Given this list of marker genes ATP5F1A, LPO, ATF7IP2, RNF166, FES, SQOR, MYO1G, LIPF, PRKAR1A, AP3D1, IFT22, TMEM163, CCL4, RHOQ, TNFSF9, ADRB2, CTPS1 (NCBI Gene Id 1503), PTP4A3 (protein tyrosine phosphatase 4A3), OPA3, LPIN1, HIF1A, MTCH1, RRAGA, CENPN, EEPD1, METRNL, IRF6, PURB, RBM14, AKNA (AT-hook transcription factor), MAP4K1, HSP90AB1, IL1RL1, FASLG, DNPH1, RTP3, GSK3B, ITGAX, GMIP, PPP3CB, KIF4A, CRLF1 (cytokine receptor like factor 1), CDC42SE1 (CDC42 small effector 1), LIPC, HGSNAT, SLC29A1, ADAM19, GLRB, ZRSR2, BMX, NCALD (neurocalcin delta), PA2G4, RAB3A, SLC2A1, GABARAPL1, MNT, SFRP2, NFIC (nuclear factor I C), CNPPD1 (cyclin Pas1/PHO80 domain containing 1), PRDM1, ETHE1, FCGRT, CEMIP2, ERRFI1, DCXR, PGLS, DSCAML1, DIAPH1, GADD45G, TAX1BP3, CCR5, EHBP1L1, PGK1, PDIA4, DDC, SLC20A1, SLC2A3, TNFAIP1, NRM, CD37, TIAM1 (TIAM Rac1 associated GEF 1), SLAMF7, GNA11, UNC119B, FAM107B, PGP, TTN, CTLA4, WNK4, ARL4C, ATP1B1, LFNG, ORAI1, OTULIN, CTSA, VIM, EIF3F, CALU, LAGE3, CCNI, SMARCD2, CHST12, KIAA0319L, THBS4, IFNG, XCL1, GRIN2D, PTPRCAP, PPP1R21, CDKN2D, DDIT4, PELO, TLN1, REEP5, PPM1G, TNNI2, FEM1A, COMMD4, RBPJL, IL21R, NAGK, ADIPOR1, ADAMTSL5, FLVCR1, SSPN, RHOH (NCBI Gene Id 399), HEPACAM2, RER1, LCN2, DENND1B, SEMA4B (semaphorin 4B), PCBP2, GLRA4, SOCS3, SNTB2, PJA1, CDKN2C, MED7, MMD, UBE2D3, FAM89B, TUBA3C, PRC1, SLAMF1, MAN2B1, PRSS58, TLE3, NAB1, PIGM, LPCAT1, DDAH2 (DDAH family member 2, ADMA-independent), SBK1, ACTB, KLHL20, GNB2, CTCF, PPP1R14C, TNFRSF13B, RPS4X, ITGB2, GLUD1, GUCD1, JUND, BHLHE40, INPPL1, CHCHD10, MRPL45, CYP24A1, SERPINE2, H1-2, HPCAL1, NRK, ANKRA2, PRKG1, ENTPD4, EIF4B, ABHD17A, FHIP1B (NCBI Gene Id 84067), PLPP2, RPS6KA1, HIP1R, TNFRSF18, DPYD, CORO1A, WDFY2, VASP, MOB1A, ARPC2, ASTN1, ZCCHC18, SLC6A15, FTH1, TNRC18, BTG1, SPG21, PTPN6, ZBTB20, LIMD1, ACTG1, PHF23, here is a description of the gene set: from publication Kinsey GR, Huang L, Jaworska K, Khutsishvili K, Becker DA, Ye H, Lobo PI, Okusa MD (PMID 22835488) Human Gene Set: GSE34006_UNTREATED_VS_A2AR_AGONIST_TREATED_TREG_DN The adenosine 2A receptor (A2AR) is expressed on regulatory T cells (Tregs), but the functional significance is currently unknown. We compared the gene expression between wild-type (WT) and A2AR knockout (KO) Tregs and between WT Tregs treated with vehicle or a selective A2AR agonist. studied in species Homo sapiens Genes down-regulated in T reg: untreated versus ZM 241385.